Given this list of marker genes CATSPER2, TEX14, PMFBP1, TTC21A, SLC6A14 (NCBI Gene Id 282807), CATIP, DNAH10, MSH5, DNAI2, CEP112, FANCB, BPY2, STX1A, FANCE, TEX15, CFAP65, SHOC1, CFAP298, MNS1, CCDC62, CCDC39, ACTL9, DNAH2, GGN, SLC11A1, SYCP3, ZSWIM7, GCNA, MAD2L2, DNAH8, FKBP6, FANCA, SPATA22, QRICH2, PPP2R3C, TAF4B, RSPH9, DNAAF11, CFAP58, AMH, SPINK2, RSPH4A, CFAP52, CFAP47, DNAH1, LRRC56, HFE, CEACAM3, KDM5D (lysine demethylase 5D), FANCI, SPAG1, WDR19, HSFY1, AURKC, LRRC23, MCIDAS (multiciliate differentiation and DNA synthesis associated cell cycle protein), DNAH9, ERCC4, FOXJ1, XRCC2, TSGA10, CDH23, KCNU1, MEIOB, AMHR2, ZPBP, SUN5, RAD51, DZIP1, STK33, M1AP, SPEF2 (NCBI Gene Id 80192), DHX37, CFTR, GATA4, ODAD2, DNAL1, PLCZ1, RPS4Y2, CYB5A, IFT74, CFAP44, WT1, RPGR (NCBI Gene Id 6110), SLX4, DNAAF4, FANCD2, ADGRG2, CCIN, TEKT3, ACTL7A (actin like 7A), CFAP61, SOHLH1, TTC29 (NCBI Gene Id 83894), TSPY1, ZMYND15, DCTN4, BRDT, VCY, SLC26A8, RSPH3, DNAH17, SYCP2, ZFPM2, GALT, PALB2, CFAP70, PDE11A, DNAH11 (dynein axonemal heavy chain 11), DNAAF5, GSTM3, GCM2, CFAP43, FSIP2, BRCA2, BRCA1, LHCGR, CFAP74, HSD3B2, EDNRA, NR0B1, NME5, TTC12, PDHA2, HYDIN, ODAD3 (outer dynein arm docking complex subunit 3), RBMY1A1, SYCE1, RPL10L, MEN1, DNAH7, STRC, IQCN, DNAAF1, MAP3K1, CTNS, MOV10L1, SOX9, USP26, CDC14A, VAMP7, AIP (aryl hydrocarbon receptor interacting protein, NCBI Gene Id 9049), OFD1, DNHD1, ARMC12, ALMS1, CEACAM6, DAZ1, SSX1, TEX11, GAS2L2, ARMC2, MSH4, TERB2, DAZ3, CFAP221, UBE2T, NME8, AR, SLC26A9, FANCG, DNAAF2, FANCM, STAG3, PTPN11, CFAP251, RSPH1, KLHL10, PRKAR1A, CFAP300, STK36, TDRD9, ODAD1, RFWD3, SPATA16, SLC9A3, BRAF, MIF, PNLDC1, RAD51C, BLM, SPAG17, BRIP1, DRC1, CYLC1, MAP2K1, DNAJB13, CDY2A, RNF212, DAZ4, ODAD4, KASH5, CCDC34, FANCF, NEK10, CATSPER1, HMOX1, WWOX, CLCA4, TGFB1, CDY1, CLDN2, CYP17A1, DNAAF6, FANCL, USP9Y, SERPINA1, SEPTIN12, KCNN4, NR5A1, AK7, CCNO, BRWD1, AKAP3, TERB1, CCDC40, SPACA1, CYP19A1, DNAH5, DPY19L2, DDX3Y, DNALI1, DAZ2, C14orf39, FBXO43, SRY, FCGR2A, FANCC, ZMYND10, CT55, ACR, C2CD6, CCDC146, GCLC, DNAAF3, DNAI1, XKRY, here is a description of the gene set: Decreased fertility in males Human Gene Set: HP_DECREASED_FERTILITY_IN_MALES studied in species Homo sapiens